Given this list of marker genes ADH1A, OAS2, KCNJ4, PSME1, PDLIM5, UBE2L6, KCNJ8, LYRM9, TRAFD1, STAT1, GABARAPL1, HSF2, here is a description of the gene set: Using high-density oligonucleotide array, we comprehensively analyzed expression levels of genes in 50 hepatocellular carcinoma (HCC) samples with positive hepatitis C virus (HCV) serology (well (G1), moderately (G2), and poorly (G3) differentiated tumors) and 11 non-tumorous livers (L1 and L0) with and without HCV infection. We searched for discriminatory genes of transition (L0 vs. L1, L1 vs. G1, G1 vs. G2, G2 vs. G3) with a supervised learning method, and then arranged the samples by self-organizing map (SOM) with the discriminatory gene sets. The SOM arranged the five clusters on a unique sigmoidal curve in the order L0, L1, G1, G2, and G3. The sample arrangement reproduced development-related features of HCC such as p53 abnormality. Strikingly, G2 tumors without venous invasion were located closer to the G1 cluster, and most G2 tumors with venous invasion were located closer to the G3 cluster (P=0.001 by Fisher's exact test). Our present profiling data will serve as a framework to understand the relation between the development and dedifferentiation of HCC. Genes up-regulated during transition from G1 (well differentiated tumor, infected with HCV) to G2 (moderately differentiated tumor, infected with HCV) in the development of hepatocellular carcinoma. from publication Iizuka N, Oka M, Yamada-Okabe H, Mori N, Tamesa T, Okada T, Takemoto N, Sakamoto K, Hamada K, Ishitsuka H, Miyamoto T, Uchimura S, Hamamoto Y (PMID 15710396) Human Gene Set: IIZUKA_LIVER_CANCER_PROGRESSION_G1_G2_UP species: Homo sapiens